Given this list of marker genes CCNB1, HNRNPU, NCAPH, SMC2, SKA3, NCAPG, RCC2, SMC5, SMC4, SIRT2, MAD2L1BP, CDCA8, AURKB, KAT2B, INCENP, SKA1, CDK1, KAT5, CDC6, RAD18, NCAPD2, NCAPH2, BIRC5, PRAP1, MAD1L1, BECN1, NCAPG2, NUMA1, SMC6, NCAPD3, here is a description of the gene set: Any process that activates or increases the frequency, rate or extent of chromosome segregation, the process in which genetic material, in the form of chromosomes, is organized and then physically separated and apportioned to two or more sets. studied in species Homo sapiens Human Gene Set: GOBP_POSITIVE_REGULATION_OF_CHROMOSOME_SEGREGATION